The following is a description of a gene set: species: Homo sapiens Olfactory receptors (ORs) are 7-pass transmembrane G protein-coupled receptors (GPCRs) located on dendritic cilia of olfactory sensory neurons (OSNs) of the olfactory epithelium. ORs are also located on cells of some other tissues. ORs bind ligands, called odorants, and activate downstream signaling through a heterotrimeric G-protein leading to opening of olfactory cyclic nucleotide-gated channels (CNG channels) and depolarization of the OSN. The human genome contains about 857 OR genes of which about 394 appear to be capable of encoding a functional OR. The remaining putative OR genes appear to be pseudogenes functionally inactivated by mutations.<br>Each OR binds a particular odorant or family of odorants. In order to provide odor discrimination, each OSN expresses only one OR gene and connects to specific olfactory bulb glomeruli according to the specific OR expressed. The choice of which OR gene to express is made by an epigenetic mechanism. Initially during OSN development, OR genes are heterochromatic. A few OR genes become weakly expressed and one then becomes dominant while all other OR genes remain silenced by heterochromatin. During activation of an OR gene, LHX2, LDB1, and EBF1 bind several (~60) intergenic enhancers located between OR genes on 18 chromosomes. The LHX2:LDB1:EBF1:enhancer complexes assemble into an interchromosomal super-enhancer that associates with the expressed OR gene and drives transcription.<br>Accumulation of OR protein in the endoplasmic reticulum membrane activates the unfolded protein response (UPR) that activates translation of ADCY3, which downregulates the histone methyltransferase KDM1A (LSD1) thereby preventing activation of any other OR genes.<br>Most OR proteins are inefficiently translocated from the endoplasmic reticulum membrane to the plasma membrane when they are expressed in heterologous cells. OSNs contain specific proteins that act as chaperones to increase subcellular translocation of at least some ORs. The short isoform of RTP1 (RTP1S) and RTP2 bind the OR in the endoplasmic reticulum, are translocated with the OR to the plasma membrane, and remain at the plasma membrane. REEP1 more weakly increases translocation of ORs by an uncharacterized mechanism. part of: Olfactory Signaling Pathway Reactome Pathway: Expression and translocation of olfactory receptors, and this is the list of marker genes: OR2A5, OR9A4, OR52N1, OR14A16, OR51H1, OR5T2, OR5G3, OR1J1, OR51A2, OR5H6, OR11H4, OR52E2, EBF1, OR2M3, OR13H1, OR51I1, OR9A2, OR8K5, OR1F12P, OR1I1, OR13C2, OR52Z1P, OR5K1, OR5B12 (NCBI Gene Id 81214), OR6N2, OR6V1, OR2D2, OR4C45, OR13C5, OR2T33, OR7D4, OR5F1, OR5A2, OR8B12, OR8G1, OR2A1, OR4C5 (NCBI Gene Id 79346), OR4N5, OR4K13, OR1J2, OR3A2, OR2AG2, OR11L1, OR10J4, OR2V1, OR5M11, OR5H1, OR2AP1, OR8B2, OR51G2, LHX2, OR51A4, OR2C1, OR10K2, OR4C6 (olfactory receptor family 4 subfamily C member 6), OR2M4, OR5P3, OR8G2P (NCBI Gene Id 282783), REEP1, OR2T27, OR10J3, OR7D2, OR8U8, OR6B1, OR4S1, OR5D16, OR10K1 (olfactory receptor family 10 subfamily K member 1), OR4A15, OR10A3, OR6C3, OR11H2, OR8J3, OR4C46, OR6B2, OR4D10, OR4F4, OR6T1 (NCBI Gene Id 79478), OR2H1 (olfactory receptor family 2 subfamily H member 1), OR5AN1, OR10H5 (NCBI Gene Id 81091), OR4D5, OR2W1, OR2T7, OR2B3, OR1L6, OR5M1, OR2L8, OR51T1, OR6C74, OR2F2, OR2I1, OR13J1, OR51E1, OR6C70, OR51J1, OR10J1, OR2G2, OR4F3, OR2A7, OR4B1, OR9I1, OR2T10, OR10C1, OR10AD1, OR10G2 (olfactory receptor family 10 subfamily G member 2), OR2K2, OR14K1, OR10G9, OR6J1, OR10H3, OR8J1, OR11H1, OR2A14, OR7A10, OR5B21, OR2S2, OR4E2, OR6P1, OR52N5, OR56A3, OR4C3, OR7C1, OR51E2, OR6C65, OR10V1, OR2H2 (olfactory receptor family 2 subfamily H member 2), OR4D1, OR5B2, OR9G1 (olfactory receptor family 9 subfamily G member 1), OR5AP2, OR2B11, OR8U9, OR9Q1, OR10H2, OR7A5, OR10A5, OR13D1, OR10S1, OR13G1, OR2B6, OR5D13, OR10D3 (NCBI Gene Id 26497), OR52E4, OR52A1, OR2G3, OR51G1, OR56B4, OR52D1, OR1L8, OR4D9, OR4K14, OR52M1, OR10A7, OR12D2, OR2L13, OR10R2, OR10P1, OR2W3, OR6C1, OR8G5, OR1G1, OR4C12, OR5K3, OR8J2, OR51B4, OR5K2, OR14C36, OR11H7, OR6K6, OR52R1, OR1D5, OR4P4, OR4C15, OR4A47, OR8U1, OR11A1, OR6B3, OR7G3, OR13A1, OR2T35, OR5AK2, OR4A4P, OR6S1, OR1E2, OR52Z1, OR4K15, OR2V2, OR6M1, OR1D2, OR8H1, OR10Q1, OR5K4, OR56A5, OR4N2, OR2A25, OR2J1, OR52I1 (olfactory receptor family 52 subfamily I member 1), OR51V1, OR6X1, OR14A2, OR8B3, OR51M1, OR1J4, OR2W5P, OR2T1, OR1F12, OR10H1, OR4K5, OR2T5, OR56B1, OR5D14, OR52K1, OR7A17, OR6Y1, OR6C75, OR1E1, OR5W2, OR2AT4, OR4A16, OR1N2, OR10A2, OR51B5, OR5AR1, OR6C2, OR52A4P, OR4M2, OR7G1, OR2J2, OR2T4, OR10AC1 (NCBI Gene Id 79304), OR1P1, OR4F5, OR10G6, OR4X2, OR13C4, OR1Q1, OR5B3, OR6C68, OR2A12, OR4D2, OR11H6, OR8B8, OR4L1, OR5M10, OR56A4, OR8D4, OR56A1, OR2T11, OR8U3, OR2AG1, OR2L2, OR5J2, OR2T29 (NCBI Gene Id 403240), OR2M5, OR10W1, OR52I2, RTP2, OR8B4 (olfactory receptor family 8 subfamily B member 4), OR52E5, OR10AG1, OR7C2 (olfactory receptor family 7 subfamily C member 2), OR5H14, OR52W1, OR7A2P, OR2Z1, OR10G4, OR13F1, OR7E24, LDB1, OR8S1, OR8D1, OR2L3, OR4E1, OR5AU1, OR4N4, RTP1, OR2T3, OR1S2, OR4K17, OR2T12, OR6C4, OR2AE1, OR4M1, OR9G9, OR5L1, OR2T8, OR2C3, OR52B6, OR1F1, OR52E8, OR1L1, OR2F1, OR10H4, OR51B2, OR8A1, OR4F15, OR2D3, OR6C6, OR2AJ1, OR10G8, OR5M8, OR11G2, OR4K3, OR12D3, OR7G2, OR4D11, OR10T2, OR10Z1, OR8K1, OR10J5, OR52H1, OR5AC2, OR8H3, OR52L1, OR14J1, OR52J3, OR2T6, OR4F21, OR4A8, OR13C3, OR52K2 (olfactory receptor family 52 subfamily K member 2), OR51S1, OR1A1, OR9K2, OR51F1, OR5V1, OR1K1, OR4C16, OR51A7, OR4F6, OR2A2, OR2T2, OR5T3, OR10G3, OR13C8, OR5A1, OR4K1, OR3A3, OR1B1, OR3A1, OR5T1, OR8H2, OR4Q3, OR1M1, OR6F1, OR4C13, OR13C9, OR5H15, OR51L1, OR1A2, OR10X1, OR4Q2 (olfactory receptor family 4 subfamily Q member 2 (gene/pseudogene)), OR5P2, OR6C76, OR2J3, OR51D1, OR8D2, OR52A5, OR51I2, OR4D6, OR4K2 (olfactory receptor family 4 subfamily K member 2), OR5C1, OR2M7, OR5M9, OR14I1, OR2A4, OR52B2, OR5B17, OR1E3, OR2L5, OR4C11, OR52N4, OR51F2, OR2B2, OR5D18, OR6Q1, OR2T34, OR10G7, OR2Y1, OR5H2, OR1L4, OR6K2, OR10A6, OR8I2, OR5AC1, OR1L3, OR51Q1, OR2AK2, OR1N1, OR9G4, OR6N1, OR8K3, OR52E6, OR1S1, OR5L2, OR4S2, OR5M3, OR4A5, OR52E1, OR4F17, OR51B6, OR1D4, OR52L2P, OR6A2 (NCBI Gene Id 8590), OR6K3, OR5I1, OR1C1, OR5AL1, OR9Q2 (olfactory receptor family 9 subfamily Q member 2), OR4X1, OR10A4, OR2M2 (olfactory receptor family 2 subfamily M member 2), OR2G6, OR52N2, OR5AS1